The following is a description of a gene set: Genes having at least one occurence of the motif CTTTGTA in their 3' untranslated region. The motif represents putative target (that is, seed match) of human mature miRNA hsa-miR-524* (v7.1 miRBase). Human Gene Set: CTTTGTA_MIR524 studied in species Homo sapiens, and this is the list of marker genes: TJP1, ATP2B2, HNRNPK, EP400, FKBP1A, GIGYF2, KMT5A, SLC30A7, HOXC8 (NCBI Gene Id 3224), FBXW11, SBF2, CDC42, LHX6, EIF4E, RARB, L3MBTL3, API5, TUFT1, ZIC1, NUP58 (nucleoporin 58), IL1A, EED, CILK1, KALRN, LRRTM3, PRRX1, CNRIP1, SRSF6, CDO1, DHX40, TAF4, IGDCC4, GALNT7, GPR180, PHF20L1, TSC22D2, SERF2, SOX4, PIP5K1A, ERCC8, IGIP, NR5A2, RBM39, TNKS1BP1 (tankyrase 1 binding protein 1), PCDH17, ADAM10, PATZ1, KAT2B, IQGAP1, WASF2, GLUD1, PEX5, GOLT1B, TCERG1L, NPAS4 (NCBI Gene Id 266743), GTDC1, CREM, MTCH1, SMURF2, SRSF2, TLE4, EBF3, MTM1, GNAO1, KHDC4, NECAP1, NHS, ZBTB7A, DIRAS2, ANP32B, HNRNPU, PTPN2, TNKS2, HECTD1, HOXD13, IRS2, QKI, PPP1R8, SLC17A6, BSDC1, GBX2, RAB40C, MITF, LRP5, LYPD3, CDC42BPB, ABCA1, MARK4, RAB21, BRD8, SOX8, CRMP1, SINHCAF, TPM3, BTBD7, PUM1, INTS6, HNRNPF, DYRK1A, MIER1, ADNP, TLX3 (NCBI Gene Id 30012), HOXB7, TNFSF11, PARVA, TSHZ1, CPEB4, MAP4K3, DUSP6, GATAD2B, NSD3, NDEL1, PPP1CB, BBOF1, NEXMIF, TGFB3, SERP1, LAMTOR5, FAM120C, SRSF10, GMEB2 (NCBI Gene Id 26205), LGR4, DACT3, UNC79, APPL1, MTPN, LRRC59, ECT2, TAB2, HNRNPA2B1, PLAGL2, ZNF106, PSD, MACIR, SOBP, PPP1R16B, PTPRE, CPLX2, FAM76A, CNTNAP3 (contactin associated protein family member 3), ING5 (inhibitor of growth family member 5), COL14A1, ZNF655, MAP3K10, PEX3, ZBTB6, NFIA, CACNA2D2, ETS2, RAC1, HES1, STAT4, PTPRU (NCBI Gene Id 10076), GNAI3, USP12, PDE2A, CCAR2, RGS7BP, CPEB3, CALU, ASTN2, VAV3, GPBP1, GSPT1, SOX9, RHO, TMEM39B, QSER1, ITGA3, GPM6A, PTPN13, PPP1R1B, IL1RAPL1, NR4A2, ARHGEF12, HEPACAM, NR2F2, IRX5, MXD1, CRHBP, CREBZF, RCAN2, NAV3, MFSD14A, LAMP2, NAA15, ZFR, TRIM23, NRK, FNBP1L, PRKRA, JADE2, ADRA2C, EPHA7, JAZF1, ARID4B, TRPS1, ID4, NKRF (NCBI Gene Id 55922), MEF2C, ZNF609, PRDM1, SESN1, NLGN3, CELF1, DCAF7, HDAC1, CRISPLD1, OTP, MTSS1, SELENOF, SELENOS, FAM131A, SCN4A, HNF1B, HIVEP2, VGLL3, CSNK1E, NACC1, MGAT2, ITGA9, AFF4, LMO4, SEH1L, NBEA, SKIL, SPEN, HIPK1 (NCBI Gene Id 23323), RBFOX1, NCOA3, ARPP19, PPP2R1B, SIPA1L2, FOXP1, SP8, ADAMTSL3, KHDRBS1, LINGO1, DIP2C, RAB11A, MDGA2, PPM1B, WDR44, SORT1, PCDH9, UBE2D3, YPEL2, KCNN4 (NCBI Gene Id 3783), CNR1, TNFAIP2, GRID1, DDHD1, CBX5, DOCK1, SP3, KLHL5, EPHA5, SON, SPTSSA, EPHA3, LMO3, ABHD4, KCNQ3, CSMD3, MOSPD2, BICRAL, PCGF3, LRRC3B, STRBP, PAPOLG, SLC25A12, SPRY4 (NCBI Gene Id 81848), USP33, LRRC32, NLK, MXI1, LRBA, SOX11, TANC1, RAP1B, SP5, JMJD1C, SCAMP5, ARHGAP33, EPB41, WDFY3 (WD repeat and FYVE domain containing 3), DKK2, TNFAIP1, MBNL2, SP1, SRSF5, SMOC2, PUM2, EDN3, NR4A3, ATXN2, ARMC8, DLG5, SPTY2D1, CETN2, KIF5A, PDCL, SLC1A3, IGSF11, PPP2CB, ATP8A1, ZNF711, JUND, HEY2, CELSR3, IWS1, KMT2E, SLITRK3, RNF111, DLX1 (NCBI Gene Id 1745), ZEB2, BZW1, BTBD10, GSPT2, CCDC91, OLFM1, DDX6, UBE2N, SMARCAD1, HADHB, HOXC13, EXOC5, PPP3CA, SMAD4, SSH3 (slingshot protein phosphatase 3), TAF12 (TATA-box binding protein associated factor 12), TMEM184B, YY1, SORBS2, GNL1, RAI14 (NCBI Gene Id 79367), ELOA, FBXO30, FOSL1, NPC1, GNAI1 (G protein subunit alpha i1), PRKAB1, KLHL32, CBX3, TEAD1, ORMDL3, CTHRC1, PFN2 (NCBI Gene Id 85837), ADAMTS6, KPNA4, RSBN1, STARD3, CEP57, VIRMA, SLC6A6, ERBIN, VPS13A, JUN, RTF1, NCOA1, ZMIZ1, DLX6, RUNX1, SESTD1, HOXB8, LTN1, MB21D2, PDZRN3, CDH9, NFIX, YWHAQ, COL11A1, ELAVL2, SP4, LARP1, LRRFIP2, RIOK1, ZFP91, PCGF2, METTL9, HMGA2, TAFA1, GADD45A, PPP5C, SMAD3, CPNE2, APPL2 (adaptor protein, phosphotyrosine interacting with PH domain and leucine zipper 2), RNF220, UQCRFS1, NXF1, KRTCAP2, ADD1, LRP1B, MYRF, ATP2B1, ZFX, CSDE1, HOXA7, SLITRK4, FOXN3, ARL4A, LEF1, P4HA2, UBE2E3, C14orf28, ADIPOR1, KCTD13, FRAT1, TCF7L2 (NCBI Gene Id 6934), NUDT4, ADGRL2, HOOK3, RANBP9, CDK2AP1, PRICKLE1, DBN1, CNPPD1, GRIA2, RCE1, PPFIA3, TBL1X, CHD7, PAX6, SNIP1, RTL6, PHF21A, PRPF38B, SSB, EIF5, CPEB2, TP53INP1, DCLK1, SEC24B, LSM14A, BAZ2B